The following is a description of a gene set: from publication Chan CW, Crafton E, Fan HN, Flook J, Yoshimura K, Skarica M, Brockstedt D, Dubensky TW, Stins MF, Lanier LL, Pardoll DM, Housseau F (PMID 16444266) Genes down-regulated in dendiritic cells from speen: interferon producing killer cells versus plasmacytoid. species: Homo sapiens To characterize differences between BALB/c splenic CD11cintB220+Gr1+ PDCs (plasmacytoid dendritic cells), CD11cintB220+CD49b+ IKDCs (interferon producing killer-dendritic cells), and CD11chighB220- cDCs (conventional dendritic cells), we performed gene expression profile analysis using Affymetrix chips. We FACS-sorted BALB/c spleen DC subpopulations. Comparison of differentially expressed genes between IKDCs and cDCs vividly revealed selective expression of multiple NK-related genes in IKDCs. These included granzymes A, B, K and M, perforin, Fas ligand, and NK receptors such as NKG2A, NKG2D, Ly49 family genes, NKR-P1, NKG7, NKp46 and Mafa (KLRG1). No NK-related genes were highly expressed in the PDCs. Human Gene Set: GSE3691_IFN_PRODUCING_KILLER_DC_VS_PLASMACYTOID_DC_SPLEEN_DN, and this is the list of marker genes: L2HGDH, TIMM9, IL36G, MAK16, POLE, GPATCH4, CES4A, SLC46A2, SERPINI2 (serpin family I member 2), PLPP1, SMARCA1, EYA4, LSM2, SFPQ, RNF144A, LRPPRC, MCM3, SH3D19, ETV6, SCARA5, PKP4, GBP7, NKX6-1, ADORA2B, AGFG1, PLXNA1 (plexin A1), SRSF7, MTFR2, BACE1, FSTL1, NLRP9 (NCBI Gene Id 338321, NLR family pyrin domain containing 9), RASAL1, SEMA5B, PPA1, CSMD3, SLC26A3, PLEK, BID, RIC3, MTM1, PLPPR5, GEMIN6, NTSR2 (NCBI Gene Id 23620), RRS1, FAM156A, TMEM169, CALHM6, U2AF1, MIXL1, UGT2B4, HSP90AA1, IQSEC2, FITM2, RRM2, FEZ1, GAMT, DDX21, HYPK, PCDHB1 (protocadherin beta 1), SRSF1, PDLIM1, RFC5, GUCY1A1, FGF1, EPHB1, ADGRA1, PPIH, PHOX2A, SMS (spermine synthase), MPHOSPH10 (NCBI Gene Id 10199), TOP2A, TMEM229B, COPS5, CLDN19, KARS1, QTRT2, HSPA9, PRPF19, PCDHB6, CDCA5, ELP1, PABPC4L, DNAJC9, PCSK5, SSC4D, COPS7A, HSPD1, NSUN2, NCAM1, SVIL, HLCS, PIK3R6, SPTBN4, MRPL21, CASP4, TIMM8A, DOHH, TMA16 (NCBI Gene Id 55319), MCU, RRP12, TMOD2, EXD1, FAM110C, RSL24D1, APBA2, YRDC, EIF5A, DDX18, CCT6A, WARS1, MDGA2, OTUD6B, SNF8, GDF11, TMEM209, N6AMT1, KDM2B, MAGOHB, NSMAF, TRIM37, SLC17A6, MFAP5 (microfibril associated protein 5), DAPL1, DOLPP1, GABRR2, GNL3, TNNT2, NDC1, TUBA1B, ADGRG6, THBS2, LRR1, MFSD2B, FHDC1, PANX2, KCNJ16, NDUFB6, ETV4, DENND3, NEUROD1, GPR179, STOML3, EIF1AY, CCDC116, TTC7B, TPST1, LAP3, CCT8, DHX9, MRPL38, CNRIP1, GPR183, GTPBP4, ADGRL4, SNIP1, RUFY2, TPO, TRUB1, TRAPPC4 (NCBI Gene Id 51399), MRPL35, DRGX, SSTR4, TMEM225, JCHAIN, CDYL2, LY6G6C, WDR75, SLC52A3, SCRN1, JADE2 (NCBI Gene Id 23338), CFAP47, TIPIN, SLC5A12, SMIM11, ZFP37, URB2, CHCHD4, VCAN, NAA20, CD53 (CD53 molecule), PRSS27, FAM111A, THRAP3, SELENOI, PRDX3, NCBP2, MKKS, FAM216B, CDK7, SERPINB9, TMEM185A, EDA, MS4A1, HS6ST3, HYKK, NDC80, CD274, CRP, SATB2